The following is a description of a gene set: Human Gene Set: HP_ABNORMAL_NUMBER_OF_TEETH The presence of an altered number of of teeth. species: Homo sapiens Abnormal number of teeth, and this is the list of marker genes: PDGFRA, SATB2, ALMS1, SH3BP2, SMAD2, MESD, CHD6, POLR1C, IRX5, SIX3, KCNA2, KCNE5, UBA5, TINF2, ERCC4, AMMECR1, SHH, RIPK4, GRIN2D, EEF1A2, VPS37D, SLC1A2, PACS2, UBR1, ADNP, XYLT1, CEP290, TFAP2A, NPHP1, IFT122, PIGL, TBL2, REV3L, ARHGEF38, DYNC2LI1, ZIC2, SMARCAL1, HECTD4, RFC2, TRAF6, DLX4, CTSC, GRHL2, RBBP8, MLXIPL, HESX1 (NCBI Gene Id 8820), WNT10B, SRD5A3, C1R, STX1A, BBS2 (NCBI Gene Id 583), CELF2, RBM28, SDCCAG8, FLRT3, APC, NHS, DUSP6, AKT1, IFT74 (NCBI Gene Id 80173), ARHGAP29, SCUBE3, CNOT1, SLC38A3, PITX2, IFT27, TCOF1, TRIO, SMG8 (SMG8 nonsense mediated mRNA decay factor), STAG2, RPS23, HCN1, DCC, SYNJ1, TTC8, SLC39A13, ANOS1, ATP6V1A, MAP3K7, FGFR2, KIF1C, BMP4, PTHLH (NCBI Gene Id 5744), BAZ1B, PIK3R1, GREM2, WRAP53, METTL27, CDON, CLIP2, HS6ST1, SMC1A, USB1, NUP85, DPP6, SCLT1, CREB3L1, ADAMTS3, PTH1R, MKS1, ANAPC1, TRAK1, PERP, RIC1, ELN, WDR35, RAD21, KCNJ2, WDR11, CHSY1, GJA1 (NCBI Gene Id 7953), IL6ST, OCRL, PUS7, FLNA (NCBI Gene Id 8272), IFT43, PPP3CA, SUMO1, GLI1, FGD1, FGFR1, CNKSR2, NAA10, SMOC2, GTF2I, MBTPS2, LEMD2, GLI2, IRF6, C1S, DALRD3, KIFBP, TRMT10A, NSD1, GABRB2, NKX2-1, MID1, MAF, GDF5, DNAJC30, RHOA, PPP1R15B, PUM1, CACNA1B, NEPRO, FZR1, B3GLCT, BCL11B, ATRIP, TRAIP, DKC1, EIF4H, CLDN1, DLL1, GNB2, TERC, GRHL3, SRCAP, PIGG, ERCC8, EVC2, FZD2, SYNGAP1, HSPG2, SLC10A7, OFD1, DVL1, KRT14 (keratin 14), CDH1, NUS1, IL11RA, NECTIN1, FKBP6, WWOX, VPS13B, DHCR7, KCNJ5, CTNND1 (catenin delta 1), GAS1, HSPA9, RECQL4, NOP10 (NOP10 ribonucleoprotein), ATP1A2, DLG1, DCAF17, GABRA5, ADAMTS2, SPRY4, NKX6-2, KCNN3, TFAP2B, TYMS, TRIM32, NELFA, DSP, BUD23 (NCBI Gene Id 84118), PPP2R3C, NECAP1, POP1, SUFU, TBX3, FBXO28, NHP2, COL9A2, CEP152, SCN8A, RMRP, ACSL4, DYRK1A, WDPCP, CTBP1, LRP4, LEMD3, POLR3A, ZFX, GABBR2, FGF10, LZTFL1, CTC1 (CST telomere replication complex component 1, NCBI Gene Id 80169), POLR3B, SCN1A, CYFIP2, TWIST2, IFT52, GTF2IRD1, DISP1, TMEM270, NPM1, COBLL1, CAMTA1, TSPEAR, TACR3 (tachykinin receptor 3), BCOR, GABRA2, DLX3, MAPK8IP3, CHD7, SZT2, AXIN2, GBA1, CPLX1, ATP6V1B2, KREMEN1, NTRK2, GHR, LETM1, WNT10A (NCBI Gene Id 93651), FOSL2, KMT2D, SCNM1, KCNB1 (NCBI Gene Id 3745), WNT5A, YWHAG, WDR19, IL17RD, EDARADD, APC2, PRKACA, CRIPTO, DNAJC21, FGFRL1, RAB23, CDH11, DVL3, FOXG1, EIF4A3, LTBP3, SLC13A5, IFT172, RPS6KA3, HNRNPK, BLM, PORCN, GTF2IRD2, NSD2, PLXND1, ARL6, AARS1, PROK2, PIK3C2A, ERCC6, BBS9, OTUD5, MSX2, FAT4, TGIF1 (TGFB induced factor homeobox 1), DNM1, BBS1, ATR, ROR2, BBS4, FGF3, DHX37, RUNX2, FOXH1, NXN, ERCC1 (ERCC excision repair 1, endonuclease non-catalytic subunit), CDC42BPB, FEZF1, PIGA, EVC, NODAL, BBS12, TRPV3, CFAP418, LRP6, POLR3GL, PCNT, HMGA2, DHDDS, TRPS1, TRIM37, KDM6A, CUX1, FOXC1, SLC25A24, FGF17, NFKBIA, TGFA, DDX59, HUWE1, NDNF, PLCH1, POLR1B (NCBI Gene Id 88998), ANKRD11, BBS5, TCF12, NCF1, PRKACB, ZMPSTE24, PARS2, ATP1A3, SOX10, PTCH1, CTSK, KDF1, CKAP2L, CLTC, ADAMTS15 (NCBI Gene Id 219807), PRKAR1A, POLR1D, KCNC2, PARN, BBS7, SEMA3A, CACNA2D1, CCDC141, CACNA1A, EDA, FGFR3, MTX2, EP300, RAD51, PAX9, CEP85L, ACOX1, LAMB3, IKBKG, CDK19, KCTD1, LMNB1, PUF60, FLNB, CBFB, SCN3A, MKKS, BBIP1, EDAR, CCDC28B, UBE3C, PLK4, CDH3, LMNA, SCAPER, KCNH1, PROKR2, RNF13, C2CD3, CCBE1, POLR3K, EXT1, FGF12, ACTL6B, DNA2, TERT, MSX1, KMT2A, SLC37A4, STIL, NEK1, POU4F1, RTEL1, AP3B2, CREBBP, CEP19, GABRG2, FGF8, LIMK1, BBS10, TP63, CENPE, POLR1A, ERCC3